Given this list of marker genes FAM167A, RUNDC3A, ZIM2, NEUROD6, NAPA, GPR171, STAT3, FOXD3, CTC1, ZMYND15, TRAP1, VGF, PAFAH1B1, DEPDC4, DDX3X, UCN, OSBPL9, USP2, MARCHF6, UBQLN2, PNRC1, GTF2A1, CSDE1, SNAP25, AGPAT4, GNG4, NF1, DLST, SYNGR3, PTPRU, NAP1L2, SLC6A5 (solute carrier family 6 member 5), HOXA3, RBMS2, BRAF, CBX3, CBX8, RBBP8 (NCBI Gene Id 5932), ARL4D, ATP10D, RCAN1, MRPS18B, HHEX, KYAT1, PPIG, TLNRD1, CCDC148, RING1, MSX2, HNRNPA2B1, HDX, DPH3, DNAJC27, DUSP1, EEF2, HS3ST2, NPTX1, SRSF1, ZBTB11, ATG5, NR4A2, LMO4, ATP6V0C, SLC6A4, DDX51, TRIB1, ERF, DMD, NOC4L, IRX4, PDP1, NUBPL, GEM, MAFF, ZBTB21, SARAF, THRAP3, CLDN6, ELOVL5, TCEAL9, MAP3K13, CHPF, SPI1, GPM6B, OSR1, SUV39H2, TAFA1, FLT1, ELL2, EGR4, RCE1, KCNK1, CDK2AP2, ING3, WDR48 (WD repeat domain 48), FAM131A, ZBTB7A, HS6ST2, ERLIN1 (NCBI Gene Id 10613), SMDT1, KCNA5, SETX, PCSK1, TMEM59L, HOXD8, MAF, RAI1, ZNF184, JOSD1, DAAM2, GLI1, RET, ZC3H10, SIK2, ZNF516-DT, PPM1A (NCBI Gene Id 5494), MYRF, MBNL1, PER1, TACR1, TIPRL, GAK, NR2E1 (nuclear receptor subfamily 2 group E member 1), GNL1, CREM (NCBI Gene Id 1390), TAOK2, AKIRIN1, TSC22D2, SEMA4C, SPHK2, KCTD8, FLRT3, CYSTM1, SMARCD1, ABHD16A, IRX6, TAPT1-AS1, OXNAD1, LETM2, GPBP1, AMER2, PPP1R12C, GPR3, PEG3, RIPK4, ADAM9, TMEM175, IRF2BPL, FGF6, THRA, MCAM, DIABLO, BCL2L13, CCND2, TSHZ2, NR4A3, PNPLA3, SLC18A2, PPARGC1A, TAPT1, PRR3, YJU2B, GLYR1, TM2D2 (TM2 domain containing 2), RANBP2, PDLIM3, TMEM256, TGIF2, RNF5, ERC1, CHGB, C11orf87 (NCBI Gene Id 399947), LTBP1, ID1, EGR3, CRH, PPP1R15A, LGR5, TPM4, DACT1, TMUB2, EGR2, ZFY, AGPAT1, YME1L1, FOS (NCBI Gene Id 2353), PPP2R2A, SCAMP5, BCL11A, PITX2, GSTCD (glutathione S-transferase C-terminal domain containing), MAP1LC3A, LCMT1, IKBKB, PNMA6A (NCBI Gene Id 84968), ASPHD1 (aspartate beta-hydroxylase domain containing 1), SDHB, FGF13, RUSC1-AS1, H4C5, ELAVL1, CALML3, VPS37B, UBAP1, EGR1, TP53INP2, PSENEN, PNMA3, CD2AP, RUSC1, FOSB, GK, ITFG2, ZNF367, CNTROB, NCALD, CLDN7, NOL4, RAB6A, U2AF1L4, AFF4, HOXC10, KLF13, SMAD1, MLF2, HHIP, TSPAN7, NFKBID, EPHA2, SIK1, ABR, AHI1, GJD2, PPP1R10, BIN1, ZZEF1, SCG2, PTGES3, DHX36, PDE4D, NUP214, SGIP1, SENP2, RPL41, ICA1, GNAS, DDX19A, TH, SLC38A2, GRM3, CEBPB, SLC25A25, HSPA9, WNT10A, CALM2, PLEKHH3, SLC31A1, CFAP68 (NCBI Gene Id 737), ID3, RPRD1A, here is a description of the gene set: Human Gene Set: CREBP1_Q2 Genes having at least one occurrence of the motif VGTGACGTMACN in the regions spanning 4 kb centered on their transcription starting sites. This matches the ATF2 transcription factor binding site V$CREBP1_Q2 (v7.4 TRANSFAC). species: Homo sapiens